Given this list of marker genes GATM, POLRMT, GALNT3, PIGA, FAM20A, SEC61A1, BCS1L (BCS1 homolog, ubiquinol-cytochrome c reductase complex chaperone), IVD, RRM2B, HNF1B (HNF1 homeobox B), SURF1, CNNM2, NPHP1, CLCNKB, CLCNKA, CEP290, COA8, OCRL, MT-TN, CTNS, BSND, FAH, SLC4A4, SLC12A3, HNF4A, here is a description of the gene set: Human Gene Set: HP_ABNORMAL_RENAL_TUBULAR_RESORPTION An abnormality of renal absorption. Abnormal renal tubular resorption studied in species Homo sapiens